The following is a description of a gene set: Enables the transfer of a solute or solutes from one side of a membrane to the other according to the reaction: nucleobase(out) + cation(out) = nucleobase(in) + cation(in). Mouse Gene Set: GOMF_NUCLEOBASE_MONOATOMIC_CATION_SYMPORTER_ACTIVITY studied in species Mus musculus, and this is the list of marker genes: Slc29a1, Slc28a3, Slc28a2b, Slc28a1, Slc28a2